Given this list of marker genes CTNNB1, GATA4, WNT4, PTGDS, NR5A1, SOX8, DHH, ZFPM2, SRY, AMH, WT1, DMRT1, FGF9, SOX9, FOXL2, RSPO1, here is a description of the gene set: Human Gene Set: WP_SOMATIC_SEX_DETERMINATION species: Homo sapiens Somatic sex determination